Given this list of marker genes Mt2, Klf2, Zfp36, Fosb, Hspa1a, Fos, Mt1, Jun, Fam53b, Clu, Hspa1b, Dusp1, Rgs1, Slc7a11, Clk1, here is a description of the gene set: Cytokines mediate cell-cell communication in the immune system and represent important therapeutic targets. A myriad of studies have highlighted their central role in immune function, yet we lack a global view of the cellular responses of each immune cell type to each cytokine. To address this gap, the authors created the Immune Dictionary, a compendium of single-cell transcriptomic profiles of more than 17 immune cell types in response to each of 86 cytokines (>1,400 cytokine-cell type combinations) in mouse lymph nodes in vivo. A cytokine-centric view of the dictionary revealed that most cytokines induce highly cell-type-specific responses. For example, the inflammatory cytokine interleukin-1β induces distinct gene programmes in almost every cell type. A cell-type-centric view of the dictionary identified more than 66 cytokine-driven cellular polarization states across immune cell types, including previously uncharacterized states such as an interleukin-18-induced polyfunctional natural killer cell state. species: Mus musculus Mouse Gene Set: CUI_MIGDC_BAFF_RESPONSE_DN from publication Cui A, Huang T, Li S, Ma A, Pérez JL, Sander C, Keskin DB, Wu CJ, Fraenkel E, Hacohen N (PMID 38057668) Genes negatively differentially expressed in cell type: MigDC (migratory dendritic cell) upon treatment with cytokine: BAFF in mouse lymph nodes in vivo.